Given this list of marker genes PALM, AIP, DAPK1 (NCBI Gene Id 1612), GBF1 (golgi brefeldin A resistant guanine nucleotide exchange factor 1), ST14, CTAG1B, TMEM94, CCL2, MMP11, PDE4A (phosphodiesterase 4A), PSD, EFNA3, TIMP3, DRG2, RABGGTA, TEF, FEV, HLA-DOB, LRRC23, IKBKE, MPP2, CSTF3, HYAL2, MYBPC2, MVK, GABRA1, TNFRSF14, BNIP1, GH2, USP11, KRT35, NELL2, PXN, CREB3, CHRND, ADCYAP1, CSNK2A2, AVPR1B, FES, SIGMAR1, PLK1, SLC30A3, DPF2, NFIC, PTPRN, KRT6A, GCM1, PAX8 (paired box 8), PIK3R3, MAMLD1, PGC, CDSN, EBI3, IRF5, PTPRU, ARHGEF2, WAS, PCDHGC3, LIF, SCN1B, PBX1, IGHMBP2, SLC18A1, CD34, CFB, SLC14A2, HSD17B3, AGPAT1, LGALS9, MADD, RING1, VPS72, FBXO46, ADAM15, CEACAM4, SIRPB1, ITIH4, KCNJ4, STIM1, AQP7 (aquaporin 7), CD8B, PLCG1, CDH15, here is a description of the gene set: species: Homo sapiens Human Gene Set: MODULE_20 Genes in the cancer module 20.